The following is a description of a gene set: studied in species Mus musculus Mouse Gene Set: MIR_455_5P from publication Chen Y, Wang X (PMID 31504780) Genes predicted to be targets of miRBase v22 microRNA mmu_miR_455_5p in miRDB v6.0 with MirTarget v4 prediction scores > 80 (high confidence targets)., and this is the list of marker genes: Add3, Luc7l3, Rc3h1, Tbl1xr1, R3hdm2, Peak1, Hecw2, Plvap, Tpcn1, Acox2, Atxn7l1, Col4a1, Kif1b, P2ry13, Cpeb1, Pcdhb3, Fez2, Aqp4, Mbnl2, Gdap2, Taf4, Myof, Usp3, Kcnj2, B3gat3, Trim33, Ptger4, Brd1, Rnf223, Cdkn1b, Corin, Clock, Ankrd44, Tnrc6b, Dpyd, Lrp2, Pja2, Cdc14b, Xrcc4, Mylip, Irf2, Chml, Arsk, Yipf6, Ccdc74a, Prelid1, Rin2, Tex12, Cacnb4, Mthfsl, Dydc1, Tnpo1, Usp9x, Dcaf5, Cdk14, Mthfs, Tjp1